The following is a description of a gene set: An intracellular signaling cassette that starts with the activation of protein kinase A (PKA), and ends with the regulation of a downstream cellular process, e.g. transcription. The PKA catalytic subunit (PKA-C) is normally present in a complex with its regulatory subunit, PKA-R. The inhibitory action of PKA-R is released upon cAMP binding, which results in the activation of PKA-C. studied in species Homo sapiens Human Gene Set: GOBP_PROTEIN_KINASE_A_SIGNALING, and this is the list of marker genes: RAB13, MROH2B, LCP1, PJA2, ADGRV1, TCP11X1, GCG, AKAP5, TTN, TCP11X2, FBN1, ADISSP, RDX, GAL, FSHR (follicle stimulating hormone receptor), TCIM, MYOM1, EZR, AKAP6, TCP11, AKAP12